Given this list of marker genes RFC2, NPPA, THSD1, HLA-DRB1, PTPN22, ELN, HLA-DPA1, SMAD4, NOTCH3, EIF4H, HEY2, VPS37D, BAZ1B, MYH11, BRAF, HLA-B, FAS, TGFB2, GATA4, DNAJC30, MYH6, TP53, SCNN1G, CTNNB1 (catenin beta 1), MYLK, CCR1, IL12A-AS1, MYH7, SON, IL10, EPHB4, ERAP1, PRTN3, SCN5A, CTLA4, MAT2A, APP, COL4A1, BRCC3, SLC2A10, SCNN1B, P4HA2, RASA1, KRAS, TLL1, IL23R, NAGA, TBX20, GNB2, STAT4 (NCBI Gene Id 6775), IKBKG, MEFV, IL12A, TGFBR1, NKX2-5, ZMPSTE24, ACVRL1, ADAMTS13, NCF1, COLGALT1, ENPP1, CITED2, TET2, MYBPC3, PRKG1, SMAD3, HLA-DPB1, RNF213, C4A, PIK3CA, ANO1, GATA6, FKBP6, GTF2IRD1, TLR4, METTL27, MLX, SH2B3, UBAC2, THPO, HTRA1 (HtrA serine peptidase 1), CLIP2, GDF2 (growth differentiation factor 2), GUCY1A1, ABCC6, SCNN1A, GTF2IRD2, MPL, IFNGR1, HBB, ACTG1, ACTA2, LOX, FOXE3, TGFBR3, STX1A, GTF2I, SMAD2, ANGPTL6, KLRC4, PIK3C2A, THSD4, TGFB3, MFAP5, BUD23, LMNA, IL12B, ACTB, NAGS, LIMK1, ADA2, TBL2, ENG, ACTC1, GLA, CALR, FBN1, JAK2, CBS, TMEM270, SMARCAL1, COL3A1, TGFBR2, here is a description of the gene set: Tissue ischemia species: Homo sapiens Ischemia is defined as a restriction of arterial blood supply to a tissue associated with insufficient oxygenation to support the metabolis requirements of the tissue. Depending on the involved tissues, clinical manifestations may include pain, pallor, lack of pulse, coldness, paresthesia, and paralysis. Additional associated manifestations include hemodynamic parameters (reduced blood pressure distal to the site of restricted arterial supply) and angiographic evidence of arterial occclusion. Human Gene Set: HP_TISSUE_ISCHEMIA